Given this list of marker genes RNF31, KDM6A, IRF1, TCF3, PIK3CG, BCL10, KMT2D, here is a description of the gene set: Decreased memory T cell proportion An abnormally reduced proportion of memory T cells compared to the total number of T cells in the blood. studied in species Homo sapiens Human Gene Set: HP_DECREASED_MEMORY_T_CELL_PROPORTION